Given this list of marker genes CD55, IL10, IL13, CD59, RAB27A, IL4, CD5L, C3, CR1L, TGFB2 (NCBI Gene Id 7042), CR1, CFH, IGHG1 (immunoglobulin heavy constant gamma 1 (G1m marker)), IL11, here is a description of the gene set: Cell killing caused by the membrane attack complex formed following complement activation. species: Homo sapiens Human Gene Set: GOBP_COMPLEMENT_DEPENDENT_CYTOTOXICITY